Given this list of marker genes PAWR, RAB1A, RAMP1, CCDC134, IGF1, TCF7L2, IL33, CCR7, ABCA7, FKTN (fukutin), TM9SF2, ABCA2 (NCBI Gene Id 23153), MIR20A, PXYLP1, MIR181B1, SLC2A10, CCL19, APCS, ITM2A, MIR323A, CCL21, SLC51B, CST3, NECAB1, AATF, ACER2, BCL2, NECAB3, GOLGA2, ITM2B, MIR298, ITM2C, JAK3, BACE2, ACOT8, MIR31 (microRNA 31), PTX3, MIR144, MGAT4D, MIR455 (microRNA 455), MIR520C, MIR644A, AGO2, MIR147A, MIR106A, GATA1, RAB1B, MIR17, NECAB2, CHP1, PLCB1, MIR153-1, NCSTN, CTNNB1, MUSTN1, SOAT1, MIR101-1, here is a description of the gene set: Any process that modulates the frequency, rate or extent of glycoprotein metabolic process. Human Gene Set: GOBP_REGULATION_OF_GLYCOPROTEIN_METABOLIC_PROCESS studied in species Homo sapiens